Given this list of marker genes TLR6, TLR2, MIR19B1, MIR19A, SSC5D, MIR105-1, TIRAP, TLR1, CD36, TLR10, CD14 (NCBI Gene Id 929), here is a description of the gene set: species: Homo sapiens Any process that results in a change in state or activity of an organism (in terms of movement, secretion, enzyme production, gene expression, etc.) as a result of a bacterial lipoprotein stimulus. Human Gene Set: GOBP_RESPONSE_TO_BACTERIAL_LIPOPROTEIN